The following is a description of a gene set: Genes having at least one occurrence of the highly conserved motif M83 TGTTTGY in the regions spanning 4 kb centered on their transcription starting sites. This matches the FOXA1 transcription factor binding site V$HNF3_Q6 (v7.4 TRANSFAC). from publication Xie X, Lu J, Kulbokas EJ, Golub TR, Mootha V, Lindblad-Toh K, Lander ES, Kellis M (PMID 15735639) species: Homo sapiens Human Gene Set: TGTTTGY_HNF3_Q6 Comprehensive identification of all functional elements encoded in the human genome is a fundamental need in biomedical research. Here, we present a comparative analysis of the human, mouse, rat and dog genomes to create a systematic catalogue of common regulatory motifs in promoters and 3' untranslated regions (3' UTRs). The promoter analysis yields 174 candidate motifs, including most previously known transcription-factor binding sites and 105 new motifs. The 3'-UTR analysis yields 106 motifs likely to be involved in post-transcriptional regulation. Nearly one-half are associated with microRNAs (miRNAs), leading to the discovery of many new miRNA genes and their likely target genes. Our results suggest that previous estimates of the number of human miRNA genes were low, and that miRNAs regulate at least 20% of human genes. The overall results provide a systematic view of gene regulation in the human, which will be refined as additional mammalian genomes become available., and this is the list of marker genes: HABP2, MTREX, BRPF1, TSHZ2, NDUFB8, TOB1, ZNF282, BMF, TCF21, TCF7L1, LAGE3 (NCBI Gene Id 8270), KIF13A (kinesin family member 13A), E2F1, CNTNAP4, PAICS, ACSM3, ECI1, PRR34, ITPR3, CDC25A, CACNG2, PCDH11Y, MPZL2, ZHX2, ENTPD7, NRXN3, PI4KB, ALOXE3, EGR2, BPIFB2, SLIT3, PITX2, PRDM1, PHF20L1, SNCB (synuclein beta), BANP, HPSE2, LEMD2, SPIB, PIH1D2, BCL6, YRDC, JPH4, GRIK2, COLGALT2, DUSP6, TMEM243, TFEC, PAIP2, GARRE1, NOS3, TUG1, ADAM15, SNCG, TGFBR1, CPNE1, DEPDC7, HOXC4, KRT77 (NCBI Gene Id 387860), DUSP1, CA14, MITF, SHROOM2, HID1, CADM3, SCO1, SMOC1, ATP2A2, PAG1, BCL11B, TFDP2, PPP1R1B, SEMA3A, HESX1, MACROH2A1 (NCBI Gene Id 9555), WDR44, CEP70, H1-4 (NCBI Gene Id 3008), NCAM1, GRB7, SVIL, PTTG2, A2M, HOMER2, NFE2L3, TRIOBP, FHDC1, NIPBL, IGFALS, ZBTB18, PTCH1, IRX5, SMARCA2, TGIF1, KCNJ2, ROBO4, MAGI1, DCT, MSI2, DCTN1, FGA, CPN1, HSPB2, SETD7, CRY2, BRD3, FAM180A, BHLHE22, LVRN, TEAD1, RTN1, NPNT (NCBI Gene Id 255743), SRPK2, GEMIN4, ADO, KIRREL3, TJP1, ASCL4, SLC16A2, HOXD4, KCMF1, MYLK, KLF3, RD3, UBE2H, PWWP3B, SERPINA6, MAPK3, TRPS1, ESAM, H1-2, GPRIN3, MARCHF5, ASPN, EVA1A, RNMT, TCF4, CTCF, MGP, TNMD, NSD1, PDIK1L, WNT5A, NPY4R, NMNAT2, LHFPL1, COL2A1, HOXA3, PTPN22, NEK8, LINC03122, BAMBI, TAPBP, GOLPH3L, RBP3 (retinol binding protein 3), RBM39, EDA (ectodysplasin A), HCAR1, PDYN, MAST4, MAP2K3, PLA2G1B, PDE3B, NR6A1, SKAP1, MXI1, ITIH1, BABAM2, TLCD5, LTBP1, GSC, SDK2, DUSP10 (NCBI Gene Id 11221), SERPINA1 (serpin family A member 1), IL18, WRN, HOXA10, NKX2-2 (NCBI Gene Id 4821), ARHGAP44, SLC29A1, ULK1 (NCBI Gene Id 8408), ASXL1, REPS2, IP6K2, CNTN1, SREK1, EDN2, APC, TF, LINC00649, RBKS, EPHA7, CITED2, EGFL7, GPR37, KLF7, SKIDA1, CCDC30, CREB3L1, RAB5A, SMAD6, ITPKB, JADE1, DIPK2B, LONRF3, FOSB, LINC00671, ATP2C1, MEIS2, OSR2, KCNJ13, ZSWIM8, RERE, EYA2, DDX6, EML3, PIP4K2B, PNMA1 (PNMA family member 1), PPP1R9B, WNK4, WBP2 (NCBI Gene Id 96240), CD19, CALCA, ENHO, NR2F2, DUSP8, MMRN2, RAD21, TMEM208, SORCS3, OMD, BRS3, MFSD13A, PRR22, IRX6, ZBTB37, ZNF462, CYP7A1, CACNA2D3, RTL3, MBD6, TMOD4, B3GALT2, TRIM54, GP2, TRPC4AP, PDLIM2, STAT5B, FCGBP, FRMD4A, SOX2, GATA6, AKTIP, YWHAG, CD68, RBFOX1, AKT2, ARHGEF6, PRMT3, SPRY1, TEAD4, SIPA1L2, NKD1 (NKD inhibitor of WNT signaling pathway 1), TRIM44, HOXC11, PSMC3IP, PSMA1, NR0B2, DNAJC22, TPI1, TFAP4, TBC1D32, ENSG00000204117, ARRB2, PCDH11X, MAB21L1, CA3, SPAG8, RFX3, EBF2, RBPJL, ACVR1, C5, RXRB, YIPF7, GRHL1, PEX5L, MAP2K7, CNOT11, MGST1, TIMP4, ZIC4, NPSR1, POU4F1, MPPED2, PPP2R2B, CPEB3, ZEB2, LINC01101, JARID2, TAGLN2, PRSS35 (NCBI Gene Id 167681), RREB1, IKZF2, AFF3, HOXC13, SHC3, DCDC1, CNPPD1, BEST3, TSHB, GTF3C1, KLF5, FIRRM, FBXL9P, ORMDL3, RAB5B, CCN1, JADE2, NR1D1, PEX16, PPTC7, JPH1, NDP, PIAS1, CHRDL1, ZNF827, AKT3, NEUROD2, CTDSP1, ALDH1A2, GABRE, RIT2, GABRA2, ITGA3, BCL11A, ROM1, PTGR3, ATP4A (NCBI Gene Id 495), PUM2, PAFAH1B3, EMSY (EMSY transcriptional repressor, BRCA2 interacting), ADAMTS10, LRRC17, RNF44, RNF167, RGS3, LGI2, EP300, SFTPC (surfactant protein C), OMG (NCBI Gene Id 4974), NOL4L, CDH10, ADTRP (androgen dependent TFPI regulating protein), CALD1, CSF2, KRT17 (keratin 17), NPEPL1, FSTL1, LY6G6E, BPTF (bromodomain PHD finger transcription factor, NCBI Gene Id 348241), LHX9, SLC39A7, GPLD1, SDR16C5, C1orf131, ZFHX3, FAM210A, MUSK, FOXP2, AP1S2, HR, PYM1, VGLL1, LGSN, CRABP2, CLUL1 (NCBI Gene Id 27098), FIGN, ZIC1, KLF6, MAPK10, HCAR2, RPS6KB1, UTP25, CCIN, ZNF395, PPP2R2A, PHOX2B, IL4, VEZF1, ERBB3, MIDEAS, GRIK1, SLC4A11, RETREG2, TENT5C, KLF3-AS1, KANK2, SLC6A14, SEMA4C, ARHGEF38, HAND2, NEFM, CFB, OMP, CHN2, EPS8L2, MEF2C, HOXC6, TSPAN7, GADD45B, AHNAK, POLD4, GAST, CEP15, TM7SF3, FOXN3, DMRT2, FGFBP3, BCL9L, SELPLG, HDGF, PNRC1, OTX2, ITPA, VSNL1, PITRM1, NCDN, ELL, VSIG2, SP4, BZW2, CMKLR2, SEMA5B, DSCAM, ARID1B (AT-rich interaction domain 1B), GAS2L2, PTPRR, DDX17, ELAVL4, GAB2, CALCOCO1, KCNIP4, MASP1, DLG2, HIP1R, PTPRG, WBP2NL, PURA, JUNB, TUBA1A, ARHGAP45, CHRM1, LUC7L, FLRT1, H2BC5, NFKBIE, SLCO2A1, ERG, EFNA1, NEUROD1, CNTNAP2, ASCL2, TAF15, IMP3, ERRFI1, CER1, PALMD, DHX29, TPMT, BTG1, NDST2, KIRREL1, NFIA, ELF4, FERD3L, UBE2B, EHF, ADGRL2, SGK1, GIPR, UBALD2, JAM3, SMAD5, CCDC117, HAVCR1, GPM6A, QRICH1, FOXP1, SEMA6A, ANGPTL1, DENND2D, EML1, GPR150, DENND2B, SYNE2, TMEM97, ATOH8 (NCBI Gene Id 84913), ID2, DLGAP4, SLC14A1, TERT, PHEX, HNF4G, DTX2, FABP1, SLC43A2, PLEKHA5, BRWD3, JAG1, MEIS1, ACIN1, KIF2B (NCBI Gene Id 84643), H1-5, SERPINF1, OGT, MED25, GPRC5C, HNRNPUL1, UBASH3A, TCF7L2, PATL1, ASB4, SRSF6, EDRF1, SOBP, ELF5, CSAD, SESN3, ZDHHC14, CDK14, BBX, ENTPD3 (ectonucleoside triphosphate diphosphohydrolase 3), PHAF1 (phagosome assembly factor 1), SFTPB, IQGAP2, CPA6, GOLGB1, ATOH1, C1orf122, AR, SLC25A16, FGL1, LZTS2, MASP2, NECAP1 (NCBI Gene Id 25977), IL11RA, CSF3, CCSER2 (coiled-coil serine rich protein 2), ANKRD13B, GJB4, OAT, CHD6, PPAT, TMEM115, PACSIN3, C14orf119, THAP11, THRA, TSHZ3, NHERF1, HS3ST5, ROBO3, CYP2A7, IKZF3, DHX30 (NCBI Gene Id 22907), CITED1, RBM47, TGM4, H1-0, UNC13D, GTF2A1, MAPRE3, CLUH, SNAP25, ZNF485, SLITRK2, PRX, TRIM37, BDH1, CDH12 (NCBI Gene Id 1010), STAG2, CLDN2, MCTP2, HNF4A, TLE3, ASB5, A1BG, SH3BP5L, METTL18, SEMA3C, RAB35, VAX1, NSD3, RFX4, H2AZ2, MTFP1, PRSS2, B4GALT2, PDK2, EFNA5, EMCN (NCBI Gene Id 51705), CDH6, ESRP2, SLC22A2, SOX14, TLL1, TMED10, SELENBP1, DSC1, RAB11B, TLE4, SHISA6, PCBP1 (NCBI Gene Id 5093), OR2L13, GRID2, ADPRM, FCHSD2, RBM11 (NCBI Gene Id 54033), DMD, AHSG, F9, WDR82, WASHC3, RNF146, KLF12, SLC38A3, MATN4, POU4F3, CBFB, IL16 (interleukin 16), PRELP, REEP4, NRG1, RPE65, NFATC4, BLOC1S2, KCNRG, SLC38A4, HMGN2, MGAT4B, MAB21L2, LINC02873, SCG3 (NCBI Gene Id 29106), IRAG2 (inositol 1,4,5-triphosphate receptor associated 2), HCRTR2, HAPLN1, FEZF2, NPVF, CREB5, ATXN7L1, CCN2, NTN1, IL5RA, SLC44A1, HTR1B, SPMIP6 (NCBI Gene Id 84688), HOXA6, OSBPL2, TFAP2D, PPP2R3A, ESR1, TFF2, BLNK, NHSL2 (NHS like 2), ZIC5 (Zic family member 5), CADM2, OVOL2, PDE6H, MGLL, NEK6, TMOD3, BRCA1, FBXW11, ITM2B, PDE4D, NBR2, FAM13C, NAV3, RGS22, MACROD2, PCSK2, SGK3, INHBA, PLA2G10, HOXA11, SLC6A1, RHBDD2, C6orf62, SOX17, KYAT1, PLXNA2, CBX6, ADARB2, ARPP21 (NCBI Gene Id 51183), BCAS1, PDGFRA, FGF14, TSC22D3, IRS1, PTGER2, NKAPD1, EPN2, LDB1, KCNK16, LBX1, LENG9, ZNF436, IGFBP1, HOXB3, TBXAS1 (NCBI Gene Id 6916, thromboxane A synthase 1), NTN4, CADM1, SLC12A1, TMEM182, EYA1, GLP2R (NCBI Gene Id 9340), GABRB1, ITIH6, PRKAG1, PDCD4, TAOK3, HCAR3, MARCHF3, TAF2, G6PC1, FOXA2 (NCBI Gene Id 3170), GBX2, FGF20, RAD23A, SIM1, ADGRB2, PURG, KMT2A, GNPAT, ABCF2, KCNIP3, DOCK9, ARHGAP32, SOX4, SOX5, C16orf89, PROC, CILK1, SUN5, NR4A3, TYRO3, SLCO1A2, GUCY2C, RNF149